The following is a description of a gene set: Systems vaccinology has emerged as an interdisciplinary field that combines systems wide measurements and network and predictive modeling applied to vaccinology. Here we used the systems vaccinology approach to study the molecular mechanisms underlying th Genes up-regulated in comparison of monocytes from influenza vaccinee at day 7 post-vaccination versus plasmacytoid dendritic cells (mDC) at day 7 post-vaccination. from publication Nakaya HI, Wrammert J, Lee EK, Racioppi L, Marie-Kunze S, Haining WN, Means AR, Kasturi SP, Khan N, Li GM, McCausland M, Kanchan V, Kokko KE, Li S, Elbein R, Mehta AK, Aderem A, Subbarao K, Ahmed R, Pulendran B (PMID 21743478) species: Homo sapiens Human Gene Set: GSE29618_MONOCYTE_VS_PDC_DAY7_FLU_VACCINE_UP, and this is the list of marker genes: SERPINB6, NUP214, ARAP3, NPL, CLIC1, SEC11A, BLVRB, HCK, SAT1, VNN2, ASGR2, TRIB1, YBX3, SLCO3A1 (solute carrier organic anion transporter family member 3A1), KIAA0513, ADAM8, MAFB, SLC31A2, ADAP2, NLRP3, S100A9, DOCK5, CXCL8, ARHGEF10L, EFHD2, CALML4, DENND3, PLAAT4 (NCBI Gene Id 5920), GCH1, HK1, NCF2, PILRA, FGL2, BCL6, TMBIM1, HK2 (hexokinase 2), MICAL2, IL1RN, APOL3, ALDH3A2, PICALM, CLEC7A, HSD17B11, FLVCR2, SIRPA, HBEGF, APLP2, CTSS, BLVRA, SCPEP1 (serine carboxypeptidase 1), RIN2, CPPED1, DPYD, CDC42EP3, DPEP2, SLC36A1, LAT2, LTA4H, FBXL5, RXRA, ASAP1, SNX2, ITGAM, CD14, MSN, RAB20, IFI30, ACSL1, TLR2, SGK1, ITGB2, TREM1, PID1, GAS7, PTPN12, CEBPB, PSTPIP1, FCN1, ARHGAP26, LST1, ENTPD1, GBP2, ALDH1A1, CHSY1, EGR1, PPM1F, LYST, CYFIP1, ZFP36L1, ASAH1, PTGER2, UBE2D1, CEBPA, HPSE, TKT, VEGFA, ZDHHC7, TMEM131L, PTP4A2, CNIH4, IER3, NACC2, TNFRSF1A, CASP1, BEST1, ALDH3B1, CSF1R, TMEM164, CYP1B1, RCBTB2, CD163, DOK1, SERPINA1, EVI2A (ecotropic viral integration site 2A), MARCKS, TNFSF13, CRISPLD2, NFIL3, TBXAS1, PLXNC1, C5AR1, SMS, TCF7L2, NAMPT, CD44, ARHGEF40, FGR, MEGF9, PCSK5, CD86, ARRB1, FPR1, SLC2A3, SMARCD3, FBN2, HCAR3, CTSL, APOL6, GMFG, RTN1, APOBEC3A (apolipoprotein B mRNA editing enzyme catalytic subunit 3A), ITM2B, CEBPD, RAB27A, KLF11, AHR, TNFRSF1B, MTMR11, S100A12, ICAM3, PXN, CD93, PLBD1, GAPDH, LIN7A, ALDOA, TBL1X, LILRB3, USP3, TUBA4A, AIF1, G0S2, PELI1, CSF3R, CD33, CKAP4, EIF4EBP2, TNFAIP2, RAB32, PYGL, FCGR2C, RNASE2, REEP4, QPCT, ALOX5, VPS37C, TMEM127, UPP1, CD1D, IGSF6, FTL, SLC7A7, GASK1B, ATG3, SPG21, CREG1, CD244, IFNGR2, EPB41L3, NAIP, RALB, AGFG1, TIMP1, HMOX1, MYO1F (myosin IF), TGIF1, WDFY3, SOD2, AOAH, SH3BP2